Given this list of marker genes FYCO1, NHS, ZNF408, CRYBA1, GALK1, NR2E3, BFSP1, GJA8, FTL, IMPG2, WFS1, CRYBB1, CRYBB2, SLC2A1, GJA1, CRYBA4, CFAP410, CRYGS, EFEMP1, PRG4, CRYBB3, GJA5, CHMP4B, MVK, HSF4, MIP, VIM, CRYGC, here is a description of the gene set: Nuclear cataract Human Gene Set: HP_NUCLEAR_CATARACT species: Homo sapiens A nuclear cataract is an opacity or clouding that develops in the lens nucleus. That is, a nuclear cataract is one that is located in the center of the lens. The nucleus tends to darken changing from clear to yellow and sometimes brown.